The following is a description of a gene set: Human Gene Set: GOBP_POSITIVE_REGULATION_OF_MUSCLE_CONTRACTION species: Homo sapiens Any process that activates or increases the frequency, rate or extent of muscle contraction., and this is the list of marker genes: GHRL (NCBI Gene Id 51738), NPPA (natriuretic peptide A), CACNB1, NPNT, HSP90AA1, EDN1 (NCBI Gene Id 1906), RHOA, ENO1, ITGA2, ACE2, RGS2, F2R, CACNA1S, CHRM3, SPHK1, UCN, MIR21, MIR1-1, ABAT, SPX, GPER1, TRPV4, GSTO1, TACR2, EDN3, TBXA2R, GHSR, CACNA1C, CTTN, ADA, PROK2, OXT, ADRA2B, ADRA1A, CHGA (chromogranin A), ATP2A1, SRF, NMU, MYOCD, TACR3, NPY2R, KIT, CACNB2, KCNQ1, ACTN3, EDN2, ATP1A1, TACR1, MAP2K1, CACNG1